The following is a description of a gene set: studied in species Mus musculus Pre-NOTCH Processing in Golgi Mouse Gene Set: REACTOME_PRE_NOTCH_PROCESSING_IN_GOLGI, and this is the list of marker genes: Notch1, Furin, Notch4, Tmed2, Notch3